Given this list of marker genes KANK1, PFN2, STAP1, EVL, ABI3, ARHGAP24, TACSTD2, here is a description of the gene set: Any process that stops, prevents or reduces the frequency, rate or extent of ruffle assembly. Human Gene Set: GOBP_NEGATIVE_REGULATION_OF_RUFFLE_ASSEMBLY species: Homo sapiens